Given this list of marker genes ADAMTS20, GNA11, BCL2, ZEB2, ADAMTS9, KITLG, here is a description of the gene set: Any process that modulates the frequency, rate or extent of melanocyte differentiation. species: Homo sapiens Human Gene Set: GOBP_REGULATION_OF_MELANOCYTE_DIFFERENTIATION